Given this list of marker genes ENSG00000285976, RNA5SP208, ZC3H11C, ADGRB3-DT (ADGRB3 divergent transcript), RPL7AP34, RPL9P18, PTP4A1, ADH5P4, RNU6-280P, ADGRB3, SPTLC1P3, EYS, SCAT8, FKBP1C, PHF3, SLC25A51P1, NUFIP1P1, EEF1B2P5, RNU7-66P, LINC02549, HNRNPDP2, GCNT1P4, ENSG00000288712, ENSG00000212229, LGSN (NCBI Gene Id 51557), ENSG00000227706, here is a description of the gene set: Human Gene Set: chr6q12 species: Homo sapiens